Given this list of marker genes H3-3A, ALX1, DGCR6, NSUN2, KANSL1, USB1, MITF, ZMPSTE24, COL3A1, ORC4, DYRK1A, TAF6, AFG2A, EDNRB, STAG2, MADD, ATP6V1B2, ALG9, TAF4, ANKRD11, OTX2, PURA, FRAS1, MTX2, PIK3R1, EDA, TRPS1, MYH3 (NCBI Gene Id 4621), PCNT, RNU4ATAC, SMARCA2, EDEM3, PRPS1, SOX10, GMNN, RECQL, CKAP2L, CLP1, HDAC4, DGCR8, ESCO2, RIPK4, HNRNPH2, MYO18B, MYMX, CRKL, NAA10, TBX1, FGF3, SLC26A2, RSPO2, RNU4-2, SRCAP, SIN3A, PPP2R3C, PAX3, UBR1, KMT2D, PRRX1, ALX4, LMNA, DGCR2, CENPJ, PPP1CB, TMLHE, RECQL4, BICRA, CTNNB1, EXT2, GHR, NOG, GJA1, ESS2, NFIX, NEXMIF, TBX4, LMBR1 (NCBI Gene Id 85501), SOX11, KDM6A, PYCR1, SIX3, SCARF2, MVK, MAPK1, FREM2, MGP, EDN3, SCNM1, GRIP1, PLEC, DDR2, RDH11, CHD6, SLC37A4, CREBBP, IARS2, NALCN, AHDC1, PHF21A, USH1G, SMCHD1, PTCH1, CWC27, TONSL, ASXL3, WNT3, TWIST2, TWIST1, TRIO, EIF5A, UBE2A, OFD1, DDB1, TGIF1, FLNB, BCR, KCNJ6 (potassium inwardly rectifying channel subfamily J member 6), TXNL4A, TP63, BRCA1, HNRNPK, here is a description of the gene set: Aplasia/Hypoplasia involving the nose studied in species Homo sapiens Human Gene Set: HP_APLASIA_HYPOPLASIA_INVOLVING_THE_NOSE Underdevelopment or absence of the nose or parts thereof.